Given this list of marker genes RACGAP1, AGFG2, SDCBP2, DSE, N4BP1, H2BC5, OSBPL3, NFIL3, GSR, RIPK1, SDC4, CCDC70, EHMT2, MFSD1, TNS2, CHSY1, HMMR, IL18RAP, TADA2A (transcriptional adaptor 2A), SLCO4C1, NCAN, LAX1, SIRT2, FAM204A, PADI2, PIK3R5, CKAP2L, ILDR1, CD86, ATAD1, DMBX1, PRR13, ITGAE, PAMR1, WDR53, CGAS, PHF5A, BSG, DDX28, SLC43A3, ARL4C, KLF13, GALNT3, TMEM154, VPS28, IGFBP4, DNMT1, MCM2, RASL11B, ABCA2, TMOD3, RFC5, LRCH3, HK2, HASPIN, NIBAN1 (niban apoptosis regulator 1), FHIP1B, AHCYL1, GNB2, FEN1, PTBP3, KLRD1, DOK1, SMIM15, RAB4A, ERCC6L, HMGCL, MTA3, RAB8A, PXYLP1, RIDA, NR3C1, MCM5, GUCD1, LYN, ABCC6, ACSL5, SNRPD1 (NCBI Gene Id 6632), PIK3R1, CENPE, CAPZB, L1CAM, RBL2, SPAG5 (sperm associated antigen 5), NDUFAF5, RFTN1, BTBD3, GOLM1, NCCRP1, ARMC7, VAMP3, ESYT1, GRAMD2B, KCTD10, KIF23 (kinesin family member 23), ADGRE5, KRTCAP2, ZFHX3, EBP, BIRC5, PWWP2B (NCBI Gene Id 170394), SEPTIN8, CSF1, CPXM1, HPS6, TXNIP, ERN1, RGS3, ZFAND4, CDC25C, ACOT8, PRELID3B, FOSL2, CCNF, CAPN2, C12orf75, STRA6, ZNF454, LGALS1, S1PR5, SELENOS, RCBTB2, HACE1, CAPG, PHGDH (NCBI Gene Id 94672), NLRC5, PPP2CB, ARL5A, PRIM1, SAR1A, ZC3H7A (zinc finger CCCH-type containing 7A), RAB11FIP4, ZCCHC18, HDHD5, CENPW, DAB2IP, MACROH2A1, GMNN, NDC80, UAP1, SLC27A4, PLK4, ZNF157, TAFA3, PTMS, TUBGCP2, RNF19B, IDH3B, KCNAB2, LCA5L, DHRS7, GABARAPL2, TWF2, PPP3CC, USP15, BICC1, GPR160, SYNGR3, TSNAX, AGT, ARHGDIA, GIMAP7, PTCD1, B3GAT3, RAD54L, CMPK1, BUD13, ACOXL, FOXM1, DCTPP1, TBC1D31, FKBP4, ATL2, ADCY8, SIRT1, USP14 (NCBI Gene Id 9097), PLEK, MACIR, CRAMP1, FCGR3A, SELENOM, GBP2 (guanylate binding protein 2), TREX1, CSNK2B, DNAJB1, OPLAH (NCBI Gene Id 55579), TKTL1, PRR11, ALG5, NUSAP1, GPANK1, ATP5F1B, CRYBG1, OSBPL5, IFITM2, PIMREG, SPAST, RAP1B, AGTRAP, here is a description of the gene set: species: Homo sapiens Genes down-regulated in Vd2 gamma delta T cells: untreated versus phorbol myristate acetate and ionomycin. The two major human gd T cell subsets, Vd1 and Vd2, display differences in tissue tropism and agonist responses, but we have little insight into global differences that may exist at the gene expression level. This is due to the small numbers of these cells that can be obtained from healthy donors, which limit comprehensive, comparative gene expression analyses. We established a culture method that expands Vd1 and Vd2 cells from the same PBL preparation to levels sufficient for sorting and microarray analysis. Although the subsets were expanded identically (anti-TCR mAb, plus IL-15), 392 and genes were identified, which were differentially expressed in the two subsets, from two donors, respectively. Approximately genes changed in both subsets following PMA/ionomycin treatment; about 50% of these genes were subset-specific. Both subsets responded to a crude LPS preparation, but only 6% of the responsive genes were the same. The differentially expressed genes were consistent with Vd2 cells being more inflammatory and Vd1 cells having more of a regulatory phenotype. Both subsets expressed transcripts encoding an array of innate and NK cell receptors, supporting the relationship of gd T cells to the innate immune system. Our results show that circulating Vd1 and Vd2 subsets in humans have considerable, inherent differences in gene expression following treatment with non-TCR agonists, supporting unique functional roles for these cells in vivo. Human Gene Set: GSE3720_UNSTIM_VS_PMA_STIM_VD2_GAMMADELTA_TCELL_DN from publication Kress E, Hedges JF, Jutila MA (PMID 16423401)